The following is a description of a gene set: Binding to a protein or a protein-containing complex to assist the protein folding process. species: Mus musculus Mouse Gene Set: GOMF_PROTEIN_FOLDING_CHAPERONE, and this is the list of marker genes: Hspa13, Wipf1, Khsrp, Pfdn1, Cct3, Hspb6, Cct4, Pdilt, Hsp90ab1, Pfdn2, Ccdc47, Cct5, Dnajb3, Hyou1, Cct7, Cct6a, Cct6b, Hspd1, Trap1, Wdr83os, Dnajb6, Tapbp, Tcp1, Clgn, Mesd, Hspa1a, Ric8b, Dnlz, Hspe1, Ric3, Tor1a, Ric8a, Cdc123, Dnajb7, Anp32e (NCBI Gene Id 99603), Hypk, Hspa4l, Zpr1, Cd74, Clpx, Dnajb8, Zmynd10, Aplf, Fkbp8, Calr, Hspa5, Dffa (DNA fragmentation factor, alpha subunit), Tsc1, Pdcl3, Hspa1l, Hspb1, Hsph1, Cct2, Calr3, Hspa8, Dnajb1, Hspa9, Cct8, Hspa4, Hsp90aa1, Hspa2, Lyrm7, Hspa1b, Hspa14, Hsp90b1